Given this list of marker genes Tnfrsf14 (NCBI Gene Id 230979), Grb2, Ptpn6, here is a description of the gene set: This event has been computationally inferred from an event that has been demonstrated in another species.<p>The inference is based on the homology mapping from PANTHER. Briefly, reactions for which all involved PhysicalEntities (in input, output and catalyst) have a mapped orthologue/paralogue (for complexes at least 75% of components must have a mapping) are inferred to the other species. species: Mus musculus Reactome Pathway: Co-inhibition by BTLA part of: Regulation of T cell activation by CD28 family electronically inferred by orthology from the curated human pathway